Given this list of marker genes NCK1, SOS1, IKBKB, TP53, PAK1, TEK, TNIP1, GRB2 (growth factor receptor bound protein 2), MAPK3, MMP2, RAC1, CASP7, MAPK11, CASP9, TIE1, GRB7, BAX, ANGPT4, CRK (NCBI Gene Id 1398), MAPK8, RELA, HRAS, MSH2, AKT1, EGFR, NOS2, MAPK12, PXN, TNIP2, DOK2, STAT5B (NCBI Gene Id 6777), ANGPT2, KRAS, CHUK, ITGB1 (NCBI Gene Id 3688), PTK2, MAPK1, NFKB1, MAPK14, FOXO1, EIF4EBP1, MYC, IKBKG, BIRC5, RS1, BAD, STMN1, SRC, NFKBIA, TNIP3, NRAS, STAT5A, PIK3R1, PTPN11, RAD51, GRB14, PIK3CA, ANGPT1, FN1, STAT3, RASA1 (RAS p21 protein activator 1), MAPK13, CTNNB1, YAP1, ANGPTL1, NOS1, MAPK9, ERBB2, here is a description of the gene set: studied in species Homo sapiens RAC1/PAK1/p38/MMP2 pathway Human Gene Set: WP_RAC1PAK1P38MMP2_PATHWAY